The following is a description of a gene set: studied in species Homo sapiens from publication Schaefer CF, Anthony K, Krupa S, Buchoff J, Day M, Hannay T, Buetow KH (PMID 18832364) IL4-mediated signaling events Human Gene Set: PID_IL4_2PATHWAY, and this is the list of marker genes: ETS1, ARG1, JAK3, CCL26, CD40LG (NCBI Gene Id 959), AICDA, COL1A2, JAK1, HMGA1, DOK2, CCL11, PTPN6, SOCS3, FES, ALOX15, RPS6KB1, MYBL1, CEBPB, RETNLB, PIK3R1, STAT5A, PIGR, BCL6, IL10, THY1, SP1, TFF3, SELP (selectin P), FCER2, IRS2, IGHG1, IL2RG, AKT1, IL4, SOCS5, OPRM1, CCL17, MAPK14, IL13RA1, SPI1, JAK2, BCL2L1, PARP14, CBL, IRF4, IL4R, SOCS1, MTOR, IL13RA2, GTF3A, STAT6, COL1A1, GRB2, ITGB3, MYB, STAT5B, EGR2 (early growth response 2), IGHG3, LTA, SHC1, IL5, IRS1, IGHE, PIK3CA